The following is a description of a gene set: Mouse Gene Set: MIR_365_3P from publication Chen Y, Wang X (PMID 31504780) Genes predicted to be targets of miRBase v22 microRNA mmu_miR_365_3p in miRDB v6.0 with MirTarget v4 prediction scores > 80 (high confidence targets). species: Mus musculus, and this is the list of marker genes: Crebl2, Rasd1, Rnf135, Cbfb, Cntf, Spty2d1, Ankrd17, Mylk, Zfp644, Epc1, Synj1, Mex3a, Ski, Smim13, Ubac2, Nkd1, Cbx5, Pak5, Usp33, Ehf, Nr3c2, E2f2, Brox, Entpd7, Abi1, Gpc6, Igf1, Ubp1, Ubxn2b, Wdr37, Arl15, Lmtk2, Rapgef4, Sgk3, Prpf40a, Tmod3, Brd10, Bcl2, Dlx3, Oaz2, Lin7a, Jade2, Slc5a8, Six4, Adm, Socs5, Dap3, Pik3r3, Prr5l (proline rich 5 like), Rps24, Mylip, Fbxo31, Trhde, Tmpo, Hoxa9, Arrb2, Ppfia2, Slc38a2, Ing3, Copa, Pgm2, Nwd2, Ywhah, Inpp4a, Sgk1, Rictor, Tiam2, Ube2d3, Tmem25, Srgap1, Lancl2, Nsd3, Acvr1, Nr1d2, Hhip, Ago2, Crebrf, Kcnj3, Ssh2, Oxr1, Kcnj2, Fam91a1, Clpsl2, Rnf152, Steap2, Arrdc3, Arhgap12, Esrra, Usp48, Add3